Given this list of marker genes Gpx3, Plscr1, Txnrd1, Fn1, Plscr3, Plscr2, Park7, P2rx2, here is a description of the gene set: Binding to a mercury ion (Hg2+). studied in species Mus musculus Mouse Gene Set: GOMF_MERCURY_ION_BINDING